The following is a description of a gene set: Human Gene Set: GOCC_STRIATED_MUSCLE_THIN_FILAMENT Filaments formed of actin and associated proteins; attached to Z discs at either end of sarcomeres in myofibrils. species: Homo sapiens, and this is the list of marker genes: TNNC2, TNNT1, LMOD2, LMOD3, TNNI1, TMOD2, TMOD1, TNNT2, LMOD1, TNNI3, TPM4, ACTA1, TNNI2, PVALEF, TPM2, TMOD3, TPM3, TPM1, TMOD4, TTN, TNNT3, TNNC1